Given this list of marker genes Zcchc13, Sra1, Ilf3, Pabpc1l, Pabpc2, Dis3l2, Pabpc4, Jmjd6, Ppie, Rbms3, Ago3, Pabpn1l (NCBI Gene Id 382035), Hnrnpu, Khdrbs2, Dhx9, Eif4a3l2, Zfr2, Mcrs1, Patl2, Rbms2, Ago1, Eif4h, Hmgb1, Rbm11, Ddx11, Cbx6, Snrpc, Rbfox2, Khdc1a, Dhx58, Pabpc1, Hnrnpc, D1Pas1, Fmr1, Rbmx, Ago4, Eif4a3, Polr2g, Hnrnpf, Cpeb2 (cytoplasmic polyadenylation element binding protein 2), Pnpt1, Cbx7, Cirbp, Dazap1, Ddx60, Cbx4, Msi2, Ifih1, Strbp (NCBI Gene Id 99105), Pabpc6, Larp4, Rps7, Piwil1 (piwi-like RNA-mediated gene silencing 1), Rigi, Tlr7, Khdrbs1, Ikzf1 (NCBI Gene Id 319751), Pabpn1, Ddx1, Rbm7, A1cf, Fxr1, Eif4b, Dlx2, Khdrbs3, Patl1, Lactb2, Syncrip (NCBI Gene Id 78260), Cnbp, U2af2, Elavl4, Rbm10, Zc3h14, Cbx8, Ssb, Msi1, Ago2, Pabpc4l, Lonp1, Pan3, Tlr8, Slirp, Pus1, Anxa1, Hnrnpdl, Paip2b, Exosc10, Zfr, Ddx3x, Aqr, Hnrnpa1, Ighmbp2, Thra, Eif4a3l1, Rbms1, Paip2, Endov, Atxn1, Pabpc5, Lsm14a, L1td1, here is a description of the gene set: Mouse Gene Set: GOMF_SINGLE_STRANDED_RNA_BINDING studied in species Mus musculus Binding to single-stranded RNA.